The following is a description of a gene set: species: Homo sapiens Human Gene Set: GOMF_OXIDOREDUCTASE_ACTIVITY_ACTING_ON_A_SULFUR_GROUP_OF_DONORS_OXYGEN_AS_ACCEPTOR Catalysis of an oxidation-reduction (redox) reaction in which a sulfur-containing group acts as a hydrogen or electron donor and reduces oxygen., and this is the list of marker genes: SELENBP1, SUMF1, PCYOX1, ERO1B, QSOX2, P4HB, QSOX1, SUOX, PCYOX1L, GFER, ERO1A